The following is a description of a gene set: Genes related to the insulin receptor pathway studied in species Homo sapiens Human Gene Set: SIG_INSULIN_RECEPTOR_PATHWAY_IN_CARDIAC_MYOCYTES, and this is the list of marker genes: GRB2, YWHAH, MAPK3, GSK3B, FOXO1, MAPK1, CAP1, YWHAG, LNPEP (NCBI Gene Id 4012), PIK3CD (NCBI Gene Id 5293), INPPL1, CBL, YWHAQ, RPS6KA1, BRD4, PTEN, PARD6A, IRS4, RPS6KB1, NPY4R, YWHAZ, PIK3CA, F2RL2, RPS6KA2, SOS2, SOS1, AKT1, SORBS1, FLOT2, PDPK1, PIK3R1, YWHAB, IGFBP1, CDC42, SFN, RAF1, CDKN2A, PTPN1, GSK3A, AKT2, AKT3, YWHAE, FLOT1, SERPINB6, IRS2, PARD3, CYTH3, SHC1, SLC2A4, IRS1, RPS6KA3